The following is a description of a gene set: Mouse Gene Set: GOBP_PEPTIDYL_HISTIDINE_MODIFICATION studied in species Mus musculus The modification of peptidyl-histidine., and this is the list of marker genes: Setd3, Dph5, Dph7, Dph1, Dph6 (diphthamine biosynthesis 6), Dph3, Dph2, Dnajc24